Given this list of marker genes Onecut2, Mef2a, Ube2d2b, Arhgef26, Ube2k, Nsd3 (NCBI Gene Id 633847), Ctxn1, Cep97, Sirt1 (sirtuin 1), Ap5z1, Lcor, Ro60, Ing4, Stxbp1, Mdk, Alkal1, Grik2, Rnf111, Msi2, Cltc, Akap6, Vdr, Sfrp1, Tm9sf3, Adamts20, Ston2, Pknox1, Dclre1c, 1700025G04Rik, Scgb2b20, Adrb1, Zfr, Stag1 (STAG1 cohesin complex component), Aloxe3, Naa15, Srsf6, Pi15, Pde7a, Cnmd, Nkrf, Arl8b, Btg3, Cenpk, Nufip2, Grp, Plpp3, Aff4, Ccdc141, Med13l, Maml3, Bnc1, Lonrf1, Mttp, Pqbp1, Serp1, Ecm2, Cep170, Map4k5, Slc7a5, Mcur1, Scgb2b7, Ube2d2a, Cdr2, Suz12, Gdnf, Gabrg2, Paip2, Ralyl, Srpk2, Ifit1bl2, Slc12a6, Il1rl1, Eef1b2 (NCBI Gene Id 80613), Abtb3, Ccl25, Unc80, Stc1, Chtop, Zbtb16, Semp2l2a, Smc6, Jakmip3, Bdp1, Ppp3ca, Zfp704, Zfp36l1, Csn3, Klhl24, Tor1aip1 (NCBI Gene Id 208263), Tpst1, Me1, Stx16, Plekha7, Taf7, Ccnyl1, Gnai3, Lhfpl3, Map4, Tle3 (transducin-like enhancer of split 3), Katnal1, Scgb2b19, Aoc3, T, Cep43, Rnf38, Ttll7, Cul4a, Il6st, Scgb2b17, Mtm1, Ube2b, Hrh1, Adcy3, Scgb1b27, Eif5, Nog, Dpy19l2, Cdh20, Vmn1r132, Rnf11, Scgb2b12, Marchf4, Apc, Gls, Tprg1l, Lrrc40, Trpc5, Ctnnd2, Cnot8, Nipbl, Gnrhr, Pcdh8, Nt5dc3, Hic2, Dip2a, Lrrc3b, Adgra2, Slc23a2 (solute carrier family 23 (nucleobase transporters), member 2), Csmd1, Ufc1, Cdk19, Tmem170b, Ipo9, Mfap3l, Lgr4 (leucine-rich repeat-containing G protein-coupled receptor 4), Cripto, Fzd2, Ggnbp1, Znrf3 (NCBI Gene Id 407821), Creb1, Mtdh, Eif2b2, Clock, Tmed10, Hmgn3 (high mobility group nucleosomal binding domain 3), Zc3h12a, Hoxc4, Ccnj, Tgfbr1, Mxi1 (MAX interactor 1, dimerization protein), Cdh2, Scgb2b15, Hnrnph2, Prdm6, Hdac9, Fcrla, Slk, Gsn, Smim10l1, Rexo2, Grem2, Higd2a, Fbxo3, Rab9b, Ptgis, Cd207, Ctr9, here is a description of the gene set: from publication Chen Y, Wang X (PMID 31504780) species: Mus musculus Mouse Gene Set: MIR_208A_5P Genes predicted to be targets of miRBase v22 microRNA mmu_miR_208a_5p in miRDB v6.0 with MirTarget v4 prediction scores > 80 (high confidence targets).